The following is a description of a gene set: Genes having at least one occurrence of the highly conserved motif M132 TCCATTKW in the regions spanning 4 kb centered on their transcription starting sites. The motif does not match any known transcription factor binding site. species: Homo sapiens Human Gene Set: TCCATTKW_UNKNOWN Comprehensive identification of all functional elements encoded in the human genome is a fundamental need in biomedical research. Here, we present a comparative analysis of the human, mouse, rat and dog genomes to create a systematic catalogue of common regulatory motifs in promoters and 3' untranslated regions (3' UTRs). The promoter analysis yields 174 candidate motifs, including most previously known transcription-factor binding sites and 105 new motifs. The 3'-UTR analysis yields 106 motifs likely to be involved in post-transcriptional regulation. Nearly one-half are associated with microRNAs (miRNAs), leading to the discovery of many new miRNA genes and their likely target genes. Our results suggest that previous estimates of the number of human miRNA genes were low, and that miRNAs regulate at least 20% of human genes. The overall results provide a systematic view of gene regulation in the human, which will be refined as additional mammalian genomes become available. from publication Xie X, Lu J, Kulbokas EJ, Golub TR, Mootha V, Lindblad-Toh K, Lander ES, Kellis M (PMID 15735639), and this is the list of marker genes: STK26, EGR3, SLC6A4, GNB2, GTF2A1, MRFAP1, TSPAN13, HOXB6, ACKR3, MYL1, SETD2, FHL3, NHLRC2, DDIT4L, ELAVL2, TNNI3K, SLC48A1, KLF14, CTNND1, PLXNB1, ZNF664, ZNF711, NASP (NCBI Gene Id 96573), SSBP3, PPP2R5C, TACC1, TMEM132A, SEPTIN4, ZNRF1, NDST2, CCDC85B, DIAPH1, CHD6, VAMP3, DUSP6, CTNND2, BSN, CCDC92, PAFAH2 (platelet activating factor acetylhydrolase 2), ENHO, SZRD1, JDP2, FGFR1, SLC25A14, KRT9, SNAPC3, KCNT2, CACNA2D3, FAM53C, ITCH, RUNX1T1, CASQ2, CTCF, CDKL5, CSDE1, CALD1, LUC7L2 (LUC7 like 2, pre-mRNA splicing factor), SORBS2, HOXA7, NUCKS1, CHD2, LRP5, MARCKS (NCBI Gene Id 4082), OTUB1, FBXL19-AS1, MAP2, ECEL1, DNASE2B, NOS1, MAPK6, DLG3, SDF2, CDR2L, LMO4, SEMA6A, SOX5, WNT3, PWP2, DPYSL2, ACVR2A, FANK1 (NCBI Gene Id 92565), IGF2BP1, IGF1, CCNT2, EGFLAM, TMTC2, MPPED2, AURKA, SCAI, MIR503HG, FOXJ3, WTAP, ZNF217, CUTA, FGF11, LRRTM4, SMYD1, SCML1, PLN, BCL2L1, SFPQ, COLCA1, MYF5, SOX2, PLAG1, ELAVL4, PFN2 (NCBI Gene Id 85837), CABP1, MAP2K5, PHF8, FAXC, TEX15, FTH1, NR3C1, USPL1, TFDP2, OLFM1, ASB7, GFRA3, IP6K2, KITLG, MATR3, LINC01597, SON, SOX4, CACNA1D, CXADR, NEXN-AS1, MYL6, DLX1 (distal-less homeobox 1), PABPC4, PNRC2, KLHL41, FGF12, CHM, RBFOX1, MLIP, ZMYND8, GMIP, RAB7A, SPAG5, TRIM25, BCL7A, SPATS2 (NCBI Gene Id 65244), LRGUK, ENAH, ZSCAN2, SOBP, NNAT, CORT, NR2C2, IL6ST, LINS1, SIAH3, CFL2, SP3, PHOX2B, CTAGE4, TSPAN6, IGFBP4, MAP3K13, NFX1, ZNF547, GNAO1 (G protein subunit alpha o1), STAG2, EIF4A1, CCDC88A, MYO1E, SHANK2, TPM3, OLFML3, DCLRE1A, SCUBE3, NR4A1, CLU, NETO1, NOL4L, BPTF, TLE3, ZMYM2, FBXW11, MRPL24, BCL6B, SPRED1, STX6, PPP1R12A, ATP5MC2, HIVEP1 (HIVEP zinc finger 1), SLC35A2, RNF111, NOB1, VSNL1 (NCBI Gene Id 7447), HSPG2, OMG, NAV1, NR4A3, RFX3, YTHDC1, DUSP10, SLC36A3, BEX1, CLASP1, FSIP2, ATP6V0B, SRSF5, GART, ANKMY2, TAB2, DST, ZMYM5, PER1, JARID2, SOX14, ZNF710, PRDM1, ZNF281, CAMLG, MAP3K20, FST, CRH, MYO18A, EML4, TFAP2D, SIPA1, C12orf50, PTGFRN, SYNCRIP, CHCHD7, BMP2, BZW2, SUPT6H, MIR137HG, ILF2, ZNF502, BEX2, JAKMIP2, NCAM2, RNF43, CELF3, BNC2, ETV5, CSTF1